Given this list of marker genes ERCC3, GTF2H1, POLR2I, POLR2B, GTF2H4, POLR2A, RNMT, SUPT5H, NCBP2, GTF2F2, POLR2D, ERCC2, GTF2H2, CCNH, POLR2H (RNA polymerase II, I and III subunit H), MNAT1 (MNAT1 component of CDK activating kinase), GTF2H3, NCBP1, CDK7, POLR2K (RNA polymerase II, I and III subunit K), POLR2L, POLR2J, POLR2E, POLR2F (NCBI Gene Id 5435), GTF2F1, POLR2G, RNGTT, GTF2H5, POLR2C, here is a description of the gene set: Human Gene Set: REACTOME_MRNA_CAPPING mRNA Capping species: Homo sapiens